The following is a description of a gene set: Medulloblastoma (D-341 MED) and rhabdomyosarcoma (TE-671) cell lines, which are resistant to either 1,3-bis(2-chloroethyl)-1-nitrosourea (BCNU) or the combination of BCNU and O6-benzylguanine (O6-BG), were generated by serial escalation of BCNU. The activities of O6-alkylguanine-DNA alkyltransferase (AGT), glutathione-S-transferase (GST), and total glutathione (GSH) of the parental, BCNU-resistant (BR), and BCNU + O6-BG-resistant (OBR) cells were measured. No significant differences in GST activity or total GSH were seen between the parental, BR, and OBR cells of both TE-671 and D-341 MED. The AGT activities of D-341 MED (BR) and TE-671 (BR) were twice those of D-341 MED and TE-671, respectively, confirming the importance of this enzyme for BCNU resistance. The D-341 MED (OBR) cells did not exhibit any AGT activity, suggesting that another mechanism must play a role in the drug resistance. Fewer DNA interstrand cross-links (ICLs) were observed in D-341 MED (OBR) than in D-341 MED after 8 h BCNU (100-400 microM) treatment. However, the amounts of DNA ICLs observed in D-341 MED and D-341 MED (OBR) were stable after 24 h. Microarray analysis showed the increased expressions of several metallothionein genes and down-regulation of several proapoptotic genes. The AGT activity of TE-671 (OBR) was 223 fmol/mg when the cells were grown in 10 microM O6-BG and decreased to about half this value when the O6-BG concentration was increased 60 microM. The AGT cDNA of TE-671 (OBR) cells was cloned and found to contain a G-to-T transversion at codon 156, resulting in conversion of glycine to cysteine (G156C). In vitro mutagenesis has shown that the G156C AGT mutant is resistant to inactivation by O6-BG. Thus, the selection of a mutant AGT with decreased sensitivity to O6-BG is a significant contributing factor to BCNU + O6-BG resistance. Human Gene Set: BACOLOD_RESISTANCE_TO_ALKYLATING_AGENTS_UP from publication Bacolod MD, Johnson SP, Ali-Osman F, Modrich P, Bullock NS, Colvin OM, Bigner DD, Friedman HS (PMID 12479369) studied in species Homo sapiens Genes up-regulated in D-341 MED (OBR) cells (medulloblastoma) resistant to both carmustine and O6-BG., and this is the list of marker genes: ACKR1, PPP2R1B, SHOX2, MDK, SGCE, MT1F, RABGAP1L, IGF1, HSPA6, PRSS12 (NCBI Gene Id 8492), LMO2, SEMA3A, CDH11, MT1A, CA2, ENC1, MT2A, HTRA1, CCN1, ID2, FBXO21, MT1X, CRIPTO3, ARSF, MYOF